The following is a description of a gene set: Human Gene Set: GOBP_POSITIVE_REGULATION_OF_GONADOTROPIN_SECRETION studied in species Homo sapiens Any process that activates or increases the frequency, rate or extent of the regulated release of a gonadotropin., and this is the list of marker genes: SMAD4, FOXL2, INHA, LEP, INHBA, INHBB